Given this list of marker genes TNNC1, MYMK, TNNI1, TNNT1, ACTN3, CAMK2B, ATP2A2 (ATPase sarcoplasmic/endoplasmic reticulum Ca2+ transporting 2), IGFBP5, MIR499A, PPP3CA, CAMK2G, MYH7, MIR208B, GTF2IRD1, here is a description of the gene set: Any process in which skeletal muscle adapts, with consequent modifications to structural and/or functional phenotypes, in response to a stimulus. Stimuli include contractile activity, loading conditions, substrate supply, and environmental factors. These adaptive events occur in both muscle fibers and associated structures (motoneurons and capillaries), and they involve alterations in regulatory mechanisms, contractile properties and metabolic capacities. studied in species Homo sapiens Human Gene Set: GOBP_REGULATION_OF_SKELETAL_MUSCLE_ADAPTATION